The following is a description of a gene set: studied in species Mus musculus Mouse Gene Set: chr18D3, and this is the list of marker genes: Redrum, Gm6944, Gm8697, Prrc1, Rbm22, Zfp608 (NCBI Gene Id 320431), F830016B08Rik, Gm23555 (predicted gene, 23555), Gm4221, Gm23270, Gm8629, Ctxn3, Aldh7a1, Gm4230, Gm18217, 9330117O12Rik, Spmip10, Marchf3, Gm34073, Gm38695 (NCBI Gene Id 105242425), Gm18087, Ccdc192, 4933434P08Rik, Iigp1c, Gm8642, Gm15345, Gm22597, Gm18929, Rps14, Chsy3, Gm18218, C330018D20Rik, Gm5821, Slc12a2, Synpo, Gm26038, Dctn4, Adamts19 (NCBI Gene Id 240324, ADAM metallopeptidase with thrombospondin type 1 motif 19), Fbn2, Myoz3, Gramd2b, Gm5970, Iigp1, 2210409D07Rik, Ndst1, Smim3, Gm19486, BC023105, Gm50288, Lmnb1, Slc27a6, Gm24183, Gm33732, Mir6355, Gm19500, Gm4841, Gm6942, Mir1258, Minar2, 4930511M06Rik, Phax, Gm18739, Gm8614, Megf10, Isoc1, Gm19519